Given this list of marker genes Bmal1, Rheb, Clock, Rfx3, Bad, Cftr, here is a description of the gene set: species: Mus musculus Any process that modulates the frequency, rate or extent of pancreatic B cell development. Mouse Gene Set: GOBP_REGULATION_OF_TYPE_B_PANCREATIC_CELL_DEVELOPMENT